Given this list of marker genes PTCH1, TDRD1, WNT1, RIPPLY1, TDRD7, PLD6, NCKAP1, BASP1, NRARP (NOTCH regulated ankyrin repeat protein), COBL, TMED2, EPB41L5, FRS2, TBXT, SMAD6, STIL, WNT7A, TDRD5, LHX1, RIPPLY2, TASOR, HOXD8, GDF3, C2CD3, TBX3, CHRDL1, NEUROG1, DCANP1, TBX6, WT1, WNT5A, TDRD6, TIFAB, MESP2, TDRKH, MESP1, SMAD4, CTNNB1, PCSK6, FZD5, SMAD2, CXXC4, CRIPTO, here is a description of the gene set: The establishment, maintenance and elaboration of a pattern along a line or a point in an embryo. studied in species Homo sapiens Human Gene Set: GOBP_EMBRYONIC_AXIS_SPECIFICATION